The following is a description of a gene set: Human Gene Set: HP_PRIMARY_AMENORRHEA studied in species Homo sapiens Primary amenorrhea, and this is the list of marker genes: FGF17, GALT, CCDC28B, AR, CPE, PRORP, DCC, PEX6, POLR3H, GPR161, SNORD115-1, FSHR, ANOS1, AXL, HDAC8, PNPLA6 (NCBI Gene Id 10908), KISS1, SPRY4, GNRH1, SRA1, NIPBL, MCM8, SMC1A, YARS1, ROBO1, NIN, MSTO1, MCM9, TP63, MSH4 (NCBI Gene Id 4438), CTDP1, POLG, TAC3, WT1, SOX10, CYB5A, SMC3, OCA2, CAV1, TACR3, MAGEL2, MRPS22, CLPP, HERC2, BRD4, GATA4, FSHB, FGFR1, PWRN1, WDR11, FLRT3, CHD7, SYCE1 (synaptonemal complex central element protein 1), NSMF, PWAR1, FGF8, DUSP6, SOHLH1, FBXO11, SNRPN, HESX1, SMCHD1, VAMP7, BMPR1B, WWOX, DHH, NPAP1, NR0B1 (NCBI Gene Id 8238), PSMC3IP, SRY, CYP17A1, CCDC141 (NCBI Gene Id 375296), PPARG, SEMA3A, LEP, POF1B, ZSWIM7, CDON, POR, DHX37, PEX1, PCSK1, ITGA8, CISD2, TRMT10A, NUP107, RAD21, NHLH2, NDN, FIGLA, TWNK, ERAL1, SNORD116-1, EIF2B1, FEZF1, IL17RD, HROB, CYP19A1, LHX4, BNC1, MAP3K1, NR5A1, EIF2B4, BBS1, STAG3, GDF9, HSD17B4, PROKR2, ZFPM2, SOX9, NOBOX, PROK2, NDNF, LARS2, MKRN3, HS6ST1 (NCBI Gene Id 9394), TAF6, ESR2, GATA3, LEPR, GNRHR, KISS1R, BMP15, RNF216, SPIDR, WNT4, ESR1, SEMA3E, SIM1, ARL6